Given this list of marker genes Sulf2, Spry4, Thbs1, Fuz, Gpc1, Fgfrl1, Creb3l1, Gata3, Ngfr, Shisa2, Sulf1, Spry1, Ofd1, Tcf7l2, Prdm14, Spry2, Apln (apelin), Wnt4, Wnt5a (NCBI Gene Id 77565), here is a description of the gene set: studied in species Mus musculus Any process that stops, prevents, or reduces the frequency, rate or extent of fibroblast growth factor receptor signaling pathway activity. Mouse Gene Set: GOBP_NEGATIVE_REGULATION_OF_FIBROBLAST_GROWTH_FACTOR_RECEPTOR_SIGNALING_PATHWAY